The following is a description of a gene set: studied in species Homo sapiens Any process that modulates the frequency, rate or extent of an endoplasmic reticulum stress-induced intrinsic apoptotic signaling pathway. Human Gene Set: GOBP_REGULATION_OF_ENDOPLASMIC_RETICULUM_STRESS_INDUCED_INTRINSIC_APOPTOTIC_SIGNALING_PATHWAY, and this is the list of marker genes: TXNDC12, SYVN1, CREB3L1, SERINC3, PARK7, BCL2L11, HYOU1, HSPA1A, PRKN, SIRT1, TMBIM6, FCGR2B, EIF2AK3, GRINA, PTPN1, ERP29, NCK2, BOK, PMAIP1, SELENOS, CREB3, APP, HERPUD1, BBC3, DDIT3, XBP1, PTPN2 (NCBI Gene Id 5771), NCK1, OPA1, RNF183, IKBKG, WFS1, BCL2L1, LRRK2, MAGEA3, PDX1